Given this list of marker genes RBM12B, LBHD1, ING5, RSKR, CSMD3, EXD3, RNU4-65P, FCN1, SLC10A5, ACSL4, CLCN6, COPA, CRISP2, RBM14, TRIM73, KCND1, LINC00474, RASIP1, ANKS6 (ankyrin repeat and sterile alpha motif domain containing 6), ZDHHC11, ZNF202, SELENOI, CCL24, MIR193A, KRTAP5-11, EEF1D, KCNQ3, MCM6, INSIG1, TMEM140, MIR129-1, DSEL, FAM90A27P, MT-TC, RNU1-74P, KIR3DL1, MYH15, C6orf58, GPAT3, CHDH, CLEC18C (C-type lectin domain family 18 member C), GPAT2, MARCHF4, SPDYE1, SMG1, KRT81, SLC34A1, SH2D4A, UVSSA, SLC7A11, SLC25A30, SDK1, SNORD30, LRRC66, ADAM32, ZKSCAN4, MIR646HG, CAPN6, AKR1D1, ZSCAN5A, MUC20, UBASH3B, TEAD1, ENSG00000252765, GSDMC, MEGF11, PRH2, UAP1, USP17L2, PTCH2, USP17L6P, INTS2, ATP13A3, SVIL-AS1, KIFC3, DHRS7C, GLDN, ZNF134, XAGE3, KIR3DL2, RN7SL607P, OSMR, OPCML (opioid binding protein/cell adhesion molecule like), GOLGA6L1, ENSG00000293132, B4GALT6, GNB3, SLC25A24, MROH7, DNAJB9, DNHD1, SEPTIN5, SLC33A1, RNU6-429P, RN7SL824P, TMEM156, HOXB1, RNA5SP190, LINC00328-2P, KCNA10, CA8, KLF3-AS1, MSANTD2, LINC02693, OLFML2A, SLFN5, KRTAP5-10 (NCBI Gene Id 387273), LINC00308, PPP1R17, PANK1, RN7SL497P, CLDN15, MIR26A1, SLC39A8, here is a description of the gene set: Normal cells require continuous exposure to growth factors in order to cross a restriction point and commit to cell-cycle progression. This can be replaced by two short, appropriately spaced pulses of growth factors, where the first pulse primes a process, which is completed by the second pulse, and enables restriction point crossing. Through integration of comprehensive proteomic and transcriptomic analyses of each pulse, we identified three processes that regulate restriction point crossing: (1) The first pulse induces essential metabolic enzymes and activates p53-dependent restraining processes. (2) The second pulse eliminates, via the PI3K/AKT pathway, the suppressive action of p53, as well as (3) sets an ERK-EGR1 threshold mechanism, which digitizes graded external signals into an all-or-none decision obligatory for S phase entry. Together, our findings uncover two gating mechanisms, which ensure that cells ignore fortuitous growth factors and undergo proliferation only in response to consistent mitogenic signals. Human Gene Set: ZWANG_EGF_INTERVAL_UP from publication Zwang Y, Sas-Chen A, Drier Y, Shay T, Avraham R, Lauriola M, Shema E, Lidor-Nili E, Jacob-Hirsch J, Amariglio N, Lu Y, Mills GB, Rechavi G, Oren M, Domany E, Yarden Y (PMID 21596316) Genes induced in the time interval between two pulses of EGF in 184A1 cells (mammary epithelium). studied in species Homo sapiens